The following is a description of a gene set: Any apoptotic process that contributes to the shaping of an anatomical structure. studied in species Mus musculus Mouse Gene Set: GOBP_APOPTOTIC_PROCESS_INVOLVED_IN_MORPHOGENESIS, and this is the list of marker genes: Lef1, Lrp5, Bmp7, Tnfrsf1b, Spi1, Foxc1, Pax8, Vdr, Jag2, Cdkn2a, Tnfrsf1a, Foxc2, Pax2 (NCBI Gene Id 207129), Ccn1, Tgfb2, Tgfbr3, Hand2, Hnf1b, Bcl2l11, Fzd5, Cryab, Fgf4, Wnt7b, Bak1, Notch1, Pml, Ppp2r1b, Cryaa, Scrib, Nkx2-5, Bmp4, Bax